The following is a description of a gene set: Mouse Gene Set: GOBP_DETECTION_OF_MECHANICAL_STIMULUS_INVOLVED_IN_SENSORY_PERCEPTION_OF_SOUND The series of events involved in the perception of sound vibration in which the vibration is received and converted into a molecular signal. studied in species Mus musculus, and this is the list of marker genes: Col11a1, Slc12a2, Adgrv1, Chrna10, Mkks, Pdzd7, Sox2, Myc, Kit, Lhfpl5, Whrn, Pcdh15, Hpn, Kcnq1, Tmc1, Chrna9, Atp2b2, Tmc2, Rest, Strc, Pjvk, Ptprq